The following is a description of a gene set: studied in species Mus musculus Mouse Gene Set: GOBP_HEME_TRANSPORT The directed movement of heme, any compound of iron complexed in a porphyrin (tetrapyrrole) ring, into, out of or within a cell, or between cells, by means of some agent such as a transporter or pore., and this is the list of marker genes: Slc48a1 (solute carrier family 48 (heme transporter), member 1), Pgrmc2 (progesterone receptor membrane component 2), Slco2b1, Abcc5, Hpx, Flvcr2, Slc46a1, Flvcr1, Abcb6